Given this list of marker genes Sec61bl, Il1rapl1, Col5a1, Api5, Furin (NCBI Gene Id 78149), Sec61b, Igfbp6, Il1rn, Pdap1, Kdr, Igfbp1, Kl, S100a13 (S100 calcium binding protein A13), Sdcbp, Egfr, Col4a1, Fgfbp1, Igfbp4, Vasn, Smn1, Itgav, Rpl37rt, Flt3, Epha7, Igf1r (insulin-like growth factor I receptor), Ptn, Erbb2, Igfbp7, Ltbp1, Itgb4, Rpl37, Nrros, Rps2, Wfikkn1, Igfbpl1, Fgfbp3, Hap1, Ptprz1, Ntrk3, Lifr, Col1a1, Lrp2 (NCBI Gene Id 99378), Il1r2, Igfbp2, Ghr, Nradd, Agrn, Cxcl13, Glg1, Rps19, Cep57, Ntf3, Tgfbr2, Fgfr2, Gpc1, Il11ra1, Epha8, Epha3, Csf1r, Tgfbr1, Insr, Nkd2, Klb, Cntfr, Bmpr2, Pdgfrb, Tsku (NCBI Gene Id 244152), Itga6, Nlrp2, Trim16, Pzp, Srpx2, Nrp1, Fgfr3, Ltbp3, Erbb3, Ntrk1, Col2a1, Sort1, Flt1, Osmr, Cd109, Fgfrl1, Igf2r, Shc1, Ghrhr, Ccn1, Il2rb, Col1a2, Il9r, Tek, Pdgfa, Epha2, Il2ra, Thbs1, Ngfr, Dusp1, Il6st, Fibp, Wfikkn2, Tgfbr3l, Reg3b, Pdxp, Hspa9, Acvr2a, Col6a1, Il1r1, Acvr1b, Htra1, Acvr2b (activin receptor IIB), Acvr1, Igfals, Eng, Itgb3, Erbb4, Fgfr1, Il6ra, Scn5a, Lrrc32, Igfbp5, Kazald1, Epha5, Fgfr4, Pcsk6, Vegfa, Col3a1, Tgfbr3 (NCBI Gene Id 73753), Il10ra, Igfbp3, Ltbp4, Tgfb3, Twsg1, Acvr1c, Cd36, Fstl4, Hyal2, A2m, Ntrk2 (neurotrophic tyrosine kinase, receptor, type 2), Flt4, Chrdl1, Il11ra2, Hax1, Pdgfra, Kit, Pdgfb, Ltbp2, Acvrl1, Il2rg, here is a description of the gene set: Mouse Gene Set: GOMF_GROWTH_FACTOR_BINDING species: Mus musculus Binding to a growth factor, proteins or polypeptides that stimulate a cell or organism to grow or proliferate.